Given this list of marker genes NOSTRIN, APOLD1, APP, AFF1, SOCS3, TIAM1, KLF2 (KLF transcription factor 2), HLA-A, ACKR1, THBD, EPHB4, MATN2, NDRG1, ADGRG6, ACTN1, IFITM3, NFKBIZ, KLF9, HDAC7, TRIM56, IGFBP7, MMRN2, HLA-B, CALCRL, TNS1, INMT, SOX7, B2M, PTPRB, CRIM1, PDE2A (NCBI Gene Id 5138), ZCCHC24, SNTB2, TSC22D1, NOS3, PTGIS, ACKR3, NR2F2, TGM2, ID1, NRP2, TLR4, CXCL1, TGFBR3, CSRNP1, AKAP12 (NCBI Gene Id 9614), PRSS23, RNASE1, SRPX, FCGR2B, TAL1, BHLHE40, ITM2B, TMSB10, CXCL11, GPM6A (NCBI Gene Id 2823), NPDC1, FBLN2, VCAM1, SPRY4 (NCBI Gene Id 81848), PTGDS, RAMP3, PARP14, SMAD6 (SMAD family member 6), PECAM1, NOVA2, EPAS1, ANKRD26, FOXC1 (forkhead box C1), ITPRIP, WWTR1, BMX, IFITM1, NCOA7, KLF4, MAPK7, SLC38A2, KRAS, FSTL3, IL1R1, IL33, NTN4, TIMP3, PTGS1, HSPB8, CEBPD, TNFSF10, CLDN11, NFIA, SPTBN1, SELE, IFI27, IL32, SPRY1, CFLAR, IFI44L, FGFR1, HYAL2, IL6ST, CXCL9, LIFR, IRAK3, SGK1, DPYSL2, TACC1, ARL4A, ENG, PRCP, GIMAP4, APOL1, FKBP1A, WARS1, VWF, PELI2, HEG1, HLA-E, GBP4, ZMYND8, BST2, C7, EHD4, PPFIBP1, TFPI, PDLIM1, C11orf96, here is a description of the gene set: studied in species Homo sapiens from publication Aizarani N, Saviano A, Sagar, Mailly L, Durand S, Herman JS, Pessaux P, Baumert TF, Grün D (PMID 31292543) Human Gene Set: AIZARANI_LIVER_C32_MVECS_3